The following is a description of a gene set: A homeostatic process involved in the maintenance of a steady state level of monoatomic anions within a cell. Monatomic anions (also called simple anions) are anions consisting of exactly one atom. Human Gene Set: GOBP_INTRACELLULAR_MONOATOMIC_ANION_HOMEOSTASIS studied in species Homo sapiens, and this is the list of marker genes: KCNQ1, UMOD, FASLG, STK39, WNK1, SLC12A5 (solute carrier family 12 member 5), TBXAS1, KCNE3, SLC12A2 (solute carrier family 12 member 2), WNK4